The following is a description of a gene set: Catalysis of the reaction: glucuronate acceptor + UDP-alpha-D-glucuronate = acceptor beta-D-glucuronoside + H+ + UDP. species: Homo sapiens Human Gene Set: GOMF_GLUCURONOSYLTRANSFERASE_ACTIVITY, and this is the list of marker genes: CSGALNACT1, UGT2B11 (NCBI Gene Id 10720), UGT1A1, UGT2A3, UGT2B4, UGT1A10, UGT2B17, B3GAT3, CHSY1, UGT3A2, EXT1, UGT2A1, UGT1A9, UGT1A8, B3GAT2, LARGE1, UGT3A1, UGT2B28, CHSY3, UGT1A6, CHPF2, EXT2, B4GAT1, LARGE2, UGT1A4, UGT2A2, UGT1A3, UGT2B10, UGT2B7, UGT1A7, EXTL1, B3GAT1, UGT1A5, CHPF, UGT2B15